Given this list of marker genes Ass1, Atp2b4, Cad, Htt, Ddah1, Otc, Aldh18a1, here is a description of the gene set: species: Mus musculus The chemical reactions and pathways involving citrulline, N5-carbamoyl-L-ornithine, an alpha amino acid not found in proteins. Mouse Gene Set: GOBP_CITRULLINE_METABOLIC_PROCESS